The following is a description of a gene set: Genes down-regulated in comparison of Jurkat T cells stimulated in the presence of PD-1 versus controls. species: Homo sapiens CD8+ T cells in chronic viral infections like HIV develop functional defects such as loss of IL-2 secretion and decreased proliferative potential that are collectively termed exhaustion1. Exhausted T cells express increased levels of multiple inhibitory receptors, such as Programmed Death 1 (PD-1). PD-1 inhibition contributes to impaired virus-specific T cell function in chronic infection because antibody-mediated blockade of its ligand, Programmed Death Ligand 1 (PD-L1) is sufficient to improve T cell function and reduce viral replication in animal models. Reversing PD-1 inhibition is therefore an attractive therapeutic target, but the cellular mechanisms by which PD-1 ligation results in T cell inhibition are not fully understood. PD-1 is thought to limit T cell activation by attenuating T cell receptor (TCR) signaling. It is not known whether PD-1 ligation also acts by upregulating genes in exhausted T cells that impair their function. Here, we analyzed gene-expression profiles from HIV-specific CD8+ T cells in patients with HIV and show that PD-1 coordinately upregulates a program of genes in exhausted CD8+ T cells from humans and mice. This program includes upregulation of basic leucine transcription factor, ATF-like (BATF), a transcription factor in the AP-1 family. Enforced expression of BATF was sufficient to impair T cell proliferation and cytokine secretion, while BATF knockdown reduced PD-1 inhibition. Silencing BATF in CD4+ and CD8+ T cells from chronic viremic patients rescued HIV-specific T cell function. Thus inhibitory receptors can cause T cell exhaustion by upregulating genes – such as BATF – that inhibit T cell function. Human Gene Set: GSE24026_PD1_LIGATION_VS_CTRL_IN_ACT_TCELL_LINE_DN from publication Quigley M, Pereyra F, Nilsson B, Porichis F, Fonseca C, Eichbaum Q, Julg B, Jesneck JL, Brosnahan K, Imam S, Russell K, Toth I, Piechocka-Trocha A, Dolfi D, Angelosanto J, Crawford A, Shin H, Kwon DS, Zupkosky J, Francisco L, Freeman GJ, Wherry EJ, Kaufmann DE, Walker BD, Ebert B, Haining WN (PMID 20890291), and this is the list of marker genes: STARD7, HMGA1, ACVR1, ADGRA3, NPC1, NAALADL1, IARS1, COG5, SLC39A14, ASPM, BTN2A1, CHST12, DOLPP1, HERPUD1, DDX1, MON1B, SLBP, PABPC4, RBM8A, CDC25A (NCBI Gene Id 993), KLK14, TNFRSF10C, CHEK1, MPHOSPH9, USP1, POLA1, THOP1, OSBP, EHBP1, POLR2B, BLMH, TRAF3, CPZ, RSRC2, CDC42SE1, MRPL3, AHNAK2, PTCD3, MCM6, GLRA3, SMC2, KPNA2, GSPT1, TRAP1, TUBGCP4, TRIM27, HMBS, SORD, UTP18, SUN1, NUP107, PMVK, DPP8, UQCC1 (ubiquinol-cytochrome c reductase complex assembly factor 1), SHLD2, TDG, NUP50, GMEB2, PPP6R1, GPHN, FTSJ3, PLAGL1, TXNL4B, LRRC59, MAP3K4, UBE2Z, HERC1, NUP93, ZNF207, RFC1, GATAD2A (NCBI Gene Id 54815), TDP1, AKR1C2, TWF2, GCFC2, MTREX, TCF3, PAK4, MCM7, TTK, LARS2, TXNRD1, PKP4, RANGAP1, IP6K1 (inositol hexakisphosphate kinase 1), ZDHHC6, ADCK2, KIF20A, SEC61A1, YTHDC2, TRMT1, MPRIP, ADH7, STUM, XPO6, TRIM28, SHMT2, OR52A1, EIF3B, PDE3B, CUL3 (NCBI Gene Id 8452), TM6SF2, PFAS, STRAP, TOPBP1, PRMT1, DHX15, SDHAP1, TMEM45A, TAOK3, KIF11, GARS1, CCT2, CAPN15 (calpain 15), YARS1, EPS15L1, SMARCA1, PRDM10 (PR/SET domain 10), NRF1, AGO3, BMPR1A, RAP1GDS1, PRSS23 (serine protease 23), PDSS2, ETNK1, ZZZ3, AHCY, CSE1L, AMPD2, RPA1, TUBGCP3, FIRRM, NARS1, PRMT5, USPL1, NELFCD, POLD1 (DNA polymerase delta 1, catalytic subunit), MTO1, TMEM183A, KDM3A, INTS15, E2F1, SMC6, CCT5 (chaperonin containing TCP1 subunit 5), TAF5, PLEKHF1, BUB1, CCDC25, CRK, NFATC3, ZFAND3, INVS, BIRC5, RPL3L, KIDINS220, RNH1, GEMIN4, HSPD1, CSTF3, ZNF236, PRC1, CAND1, GLS, DKC1, TUBG1, KIF18B, SIN3B, MAN1C1 (NCBI Gene Id 57134), DIAPH2, CTCF, DCTD, SLCO3A1, MFNG, CARS2, MCM2, RPS13, SOCS2, MXI1, TBC1D4, SLC5A4, GALNT14, EDC4 (enhancer of mRNA decapping 4), C1QTNF3, ZFYVE26, KIF2C, ARSB, WRN, AIFM1, ME2, SAR1A, KANSL3, APOF, RIN2, PHKA1, EFEMP1, PLCB1, EFL1, TATDN2, LEMD3 (NCBI Gene Id 23592), NCAPD3